The following is a description of a gene set: To investigate the functional properties of Ly6G+ DC, we employed GeneChip analysis to compare the gene expression profiles between Ly6G+ DC and Ly6C- DC. Human Gene Set: GSE28408_LY6G_POS_VS_NEG_DC_UP studied in species Homo sapiens from publication Matsushima H, Geng S, Lu R, Okamoto T, Yao Y, Mayuzumi N, Kotol PF, Chojnacki BJ, Miyazaki T, Gallo RL, Takashima A (PMID 23305731) Genes up-regulated dendritic cells: Ly6G+ versus Ly6G-., and this is the list of marker genes: FOSL1, NSUN5P1, KAT6A, MYLIP, H2AC6, ATP7A, AMZ2, LYRM9 (NCBI Gene Id 201229), PBX1, MAN2C1, CASK (NCBI Gene Id 8573), KDM6A, YPEL5, MZF1, ATP6V0A1, GABARAPL1, ITM2A, SIDT2, MCL1, ICAM1, CLOCK, PTGER4, ANKRA2, PCYOX1L, PLK3, ZNF337, RGS2, TIAM1, SEMA4A, TOB1, PCNP, TM2D3 (NCBI Gene Id 80213), ZNF175, TNPO2, ABCA5, RXRB, FGF4, PIK3R3, SLC46A3 (solute carrier family 46 member 3), ABCA7, RPS27A, LY75, TRIAP1, SNX2, NCOA1, RAPGEF2 (Rap guanine nucleotide exchange factor 2), GMPR2, ZNF75D, ZSCAN9, HERPUD1, TMA7, TXLNGY, SLC2A11, TP53BP1, RPS27L, CBX7, TCF25, CCNG1, SATB1, ABCG1, CDC42BPA, KIF3A, GPX7, KLHL20, EZH1, RGS1, G3BP2, TRAK1, PER1, NPIPA1, KCNJ2, BCL2, CTSF, CPNE7 (copine 7), ASCC3, NADSYN1, CLUAP1, MXI1, PKD2, AKR1C3, CDK2AP1, CLSTN3, NDST3, NEDD9, ATF7IP2, MXD4, TNIK, TMEM9B, AKAP10, NFX1, CXCR4, SLC52A2, ANKRD46, SP110, CDIP1 (NCBI Gene Id 29965), AMT, TNFAIP3, DDX42, OFD1, BCL6, PIGL, GNA15, PPM1D (NCBI Gene Id 8493), RIOX2, LTBP3, FYCO1, CERS6, RAB3GAP1, PGAP1, ITGAM, PPP1R3D, ZNF276, PUS1, SOS2, LAMP1, TSPAN32, SENP6, NME3, BSDC1, SEC31B, CD7, TMEM134, SAT1, PCNX2, RALGAPB, ARIH2, NOL3, TYK2, NSUN5P2, GPR171, ATRAID, CD70, GLO1, RPS6KA5, IER5, SGSM2, TRMO, BAG3, HOXB2, ENTPD4, LAX1, ARL6IP5, IRF9, NXF1, FHIP2B, FDXR, CD44, RAPGEF6, PSTPIP2, CA11 (NCBI Gene Id 770), ATP1B1, KDM5B, GPR75, PPP2R2D, ISCU, TRIM44, SORL1, KDM5D, ZNF302, NR1D2, BIN3, OSBPL3, TGFBR2, PHLDA2, GARRE1 (NCBI Gene Id 9710, granule associated Rac and RHOG effector 1), TIGAR, FOXO1, SP100, GOLGA1, GUCY1A1, PRKCA, HTR4, C11orf21, RPL23 (NCBI Gene Id 9349), ZFC3H1, PER3, RGS16, ANKRD11 (ankyrin repeat domain containing 11), PSEN2, RNASEL, GRB10, NMRK1, ANAPC13, GPX1, GALNT7, PCBP4, TMUB2, TSPYL2, H2BC5, IL2, PACSIN2, TRIM22, STK38, BDH2, CEACAM1, ZBTB40, MAN2A2